The following is a description of a gene set: Reactome Pathway: SLC-mediated transport of organic cations The organic cation transporters comprise three SLC22 members, OCT1-3. They can transport a wide range of organic cations including weak bases. All transport by OCTs is electrogenic, sodium-independent and bidirectional. Two further organic cation transporters mediate transport of ergothioneine and carnitine (Koepsell H and Endou H, 2004). species: Homo sapiens part of: SLC-mediated transmembrane transport, and this is the list of marker genes: SLC22A16, SLC25A26, RSC1A1, SLC22A2, SLC22A4, SLC22A3, RUNX1, SLC22A1, SLC22A15, SLC22A5, SLC67A1, SLC14A2, SLC47A2, SLC47A1, SLC14A1